Given this list of marker genes SGSH, HYAL1, ARSB, GALNS, NAGLU, HGSNAT, GLB1, IDUA, IDS, GNS, GUSB, here is a description of the gene set: The mucopolysaccharidoses (MPS) are a group of rare, inherited lysosomal storage disorders caused by deficiencies of enzymes catalyzing the stepwise degradation of glycosaminoglycans (GAGs, originally called mucopolysaccharides) (Neufeld & Muenzer in Scriver et al. 2001). Catabolism of the GAGs dermatan sulfate, heparan sulfate, heparin, keratan sulfate, chondroitin sulfate or hyaluronan may be blocked at one or more steps, resulting in lysosomal accumulation of GAG fragments of varying size. Over time these collect in the cells, blood and connective tissues ultimately resulting in progressive irreversible cellular damage which affects appearance, physical abilities, organ and system function, vision, and usually mental development. Life expectancy is also reduced. There are 11 known enzyme deficiencies that give rise to 7 distinct MPS. These disorders are biochemically characterized by elevated levels of partially or undegraded GAGs in lysosomes, blood, urine and cerebro-spinal fluid. The MPS are part of the lysosomal storage disease family, a group of about 50 genetic disorders caused by deficient lysosomal proteins (Ballabio & Gieselmann 2009). Reactome Pathway: Mucopolysaccharidoses part of: Diseases of carbohydrate metabolism studied in species Homo sapiens